Given this list of marker genes JAM2, GMPPB, AKT1, NDE1, POMGNT1, POLG, GTPBP3, FKRP, PIK3CA, TERT, COASY, SMARCE1, COX10, DCC, NF2, TRAF7, EXOC7, RANBP2, SETD5, GFAP, TUBB3, EXOC2, POMK, CP, POMT1, MED17, SCP2, MFF, TREM2, CMPK2, SLC2A1, PIK3C2A, SMARCB1, SMO, MTRFR (NCBI Gene Id 91574), TUBB2B, TUBA1A, FTL, PTCD3, POMT2, TWNK, PTCH1, GSX2, BAP1, MYORG, HEXB, CLN8, PDGFB, SUFU, here is a description of the gene set: Human Gene Set: HP_ABNORMAL_THALAMUS_MORPHOLOGY species: Homo sapiens Abnormal thalamus morphology An abnormality of the thalamus.